Given this list of marker genes KLF4, KDR, BCL11B, HMGN1, BAK1, FZD5, BAX, VEGFA, here is a description of the gene set: The process occurring during the post-embryonic phase whose specific outcome is the progression of the camera-type eye over time, from its formation to the mature structure. studied in species Homo sapiens Human Gene Set: GOBP_POST_EMBRYONIC_CAMERA_TYPE_EYE_DEVELOPMENT